The following is a description of a gene set: studied in species Homo sapiens Human Gene Set: chr19q13, and this is the list of marker genes: ZNF180, MYREM, HNRNPL, IGFL1P2, SIGLEC5, ZNF329, AP2S1, ZNF321P (zinc finger protein 321, pseudogene), ZNF574, ZC3H4 (zinc finger CCCH-type containing 4), C19orf18, ZNF606, BLOC1S3, ZFP28, IRF2BP1, GPR42 (G protein-coupled receptor 42), MIR8077, CEACAMP10, ZNF607, MIR6887 (NCBI Gene Id 102466205), KCNN4, DUXA, ZNF223, UBE2CP5, SYCN, HAUS5-DT, MIR517C, RNU6-841P, COX6B1, SIGLEC20P, LIN37, SIGLEC8, RPS29P24, RPS10P28, VASP, LINC01531, MIR6719, IFNL1, ARHGEF1, MIR518A1 (NCBI Gene Id 574488), MIR371B, RNU6-1041P, RPL12P41, IGSF23, RNU6-611P, RASIP1, FUZ, OSCAR, ZNF835, SIGLEC10-AS1, ZSCAN5C, KLK12, LINC01480, MIR8074, LETM1P2, CYP2A13, ISOC2, RPS11, CYP2G2P, ZNF667-AS1, ZNF471, KLK1, MIR4754, ZFP36, GCM1P1, LYPD5, ENSG00000221125, MYADM-AS2, ZNF584-DT, SNORD35B, ERICH4, IRGC, BLVRB, ZNF45, TMEM160, CCDC9, KIR2DL3, ZNF552, SLC8A2, COQ8B, MIR6804, CD177, PSG2, PRPF31, ZNF211, ZNF599, PSENEN, ZNF135, ZNF230-DT, RPS4XP21, VN1R4, PRR13P5, LIN7B, RN7SL154P, SIGLEC17P, LSM14A, ZNF8 (NCBI Gene Id 7554), FFAR2, ETV2, PLA2G4C-AS1, ZNF585B, PSMC4, VSIG10L, PKMYT1AR, ZNF461, IGFL1, RPS9, FXYD3, IGFLR1, ZNF667, PTOV1, RYR1, TMC4, ZNF134, NAPA, BICRA-AS2, AURKC, CGB1, SYNGR4, MIR6800, DLL3, GARIN5B, KIR2DS4, RPS12P31, ZNF841, ZNF324, VN2R19P, RPS4XP23, BICRA-AS1, RTN2, LILRB3, ATF5, MIR8085, KIR3DL2, DEDD2, PNMA8B, ZNF8-DT, NTF6A, SELENOV, NAPSB, MIR6799, LILRA4, EMP3, GSK3A, KLK9 (kallikrein related peptidase 9), KIR3DL3, LINC01595, MIR1283-1, LINC01837, SNORD88B, FBXO27, PAF1, ZNF8-ERVK3-1, CHST8, ZFP82, TPM3P6, KLK6, CTBP2P7, NAT14 (N-acetyltransferase 14 (putative)), MIR515-1, ZSWIM9, SIGLEC14, FPR2, ACP7, MIR525, ZNF807P, CCDC8, ZNF30-AS1, CD177P1, CEACAMP9, RPL9P33, CEACAM22P, PCAT19, CDC42EP5, FAAP24, PSG6, CCDC61, SIGLEC7, BBC3, PHLDB3, KLK8, APOC4-APOC2, ZNF528-AS1 (ZNF528 antisense RNA 1), ZNF415, ZNF568, CLEC11A, FAM187B, DYRK1B, PDCD2L, ZNF586, ZNF383, ZFP14, SRRM5, MIR520C, ZNF222-DT, CLPTM1, MIR6802, ZSCAN1, A1BG-AS1, CEACAMP6, MIR516A1, APLP1, PMIS2, WDR62, C19orf47, C19orf73, NFKBIB, ENSG00000267698, LINC02965, ZNF573, RPL13A, MIR6805, C19orf84, ZNF324B, PLEKHA3P1, ALKBH6, HNRNPDLP4, ZIM2-AS1, ZNF428, VRK3, RN7SL34P, CEACAM7, PSG8, RPS29P30, DMWD, BIRC8, TRAPPC6A, LRFN1, MSRB1P1, MIR512-2, COX6B2, SHANK1, PNKP, APOC1P1, ARPC1AP2, MIR99B, MIR518F, RCN3, PEPD, IFNL4, COX7A1, LENG8-AS1, MIR935, ZNF132-DT, CABP5, CYP2A7P1, ZNF418, KLK13, RPL18, PPP6R1, ACTMAP, SIPA1L3, LINC00904, LGI4, FOSB, NR1H2, ZNF787, RNU6-165P, RPL31P60, FKBP1AP1, SNORA68B, ZNF497, LAIR1, MIR5196, SPACA6, ZNF577, VN1R104P, RFPL4AL1, LENG8 (leukocyte receptor cluster member 8), SIGLEC22P, NIFKP6, CEBPA-DT, ZNF793-AS1, ZNF566, MIRLET7E, MIR522, CEACAM6, CALM3, ACTN4, SYT3, ENSG00000267053, ZNF350-AS1, SMG9, ENSG00000269091, ENSG00000298539, SPTBN4, LINC01864, MIR6797, ZNF507, RPS15AP36, SNORD88A, A1BG, ZNF818P, ZNF579, EID2B, CCDC106, ZNF550, HSPBP1 (NCBI Gene Id 29987), FFAR1, TDRD12 (tudor domain containing 12), GRAMD1A-AS1, PLEKHA4, LIPE, SLC25A36P1, ACP4, PAK4, KIR2DP1, ZNF264, SNRPD2, ZNF226, FPR3, USP29, PINLYP, YIF1B, LIPE-AS1, ZNF470, DKKL1, ZSCAN4, KLK5, RPL21P131, NDUFV2P1, RN7SL364P, RRAS, ZNF613, MIR643, CGB3, KLK11, ZNF227, VN2R17P, FBL, CADM4, SNORD23, ZNF284, ZNF888-AS1, LILRA5, KIR2DL1, SHKBP1, ZNF761, ZNF460-AS1, RNF225, ZNF569, LAIR2, ATP1A3, ZNF582-DT, HSPB6, LYPD4, LINC03078, CLDND2, ZNF285BP, SYT5, VN1R2, LILRA1, PRKCG, ENSG00000269194, ZNF382, PSG11, ENSG00000268833 (novel transcript, antisense to CEACAM6), SNORA70, LILRA6, FAM98C, DBP, LINC00665, NTF6G, SNRNP70, FBXO17, PTH2, ETHE1, SBK3, ZNF548, ENSG00000267058, CYP2F2P, ZNF444, MIR526A2, ZNF790, RNU6-980P, IFNL2, WDR87BP, EXOC3L2, ENSG00000267024, RN7SL566P, SPACA6-AS1, LSR, SIGLEC6, PDCD5, SEC1P, ZIM3, EGLN2, CEACAMP4, ZSCAN5DP, ZNF181 (zinc finger protein 181), ZNF805, ENSG00000268595, THAP8, ZNF221, GPR32, MIR521-2, RPS3AP50, IL11, ZNF587, RPS19, ITPKC, PSMD8, IL4I1, ZNF793, MIR320E, ZNF582, SYNE4, TTC9B, LNROP, ZNF790-AS1, MZF1, ZNF808 (zinc finger protein 808), GPR32P1, ZNF420, RELB, KLK15, RUVBL2, MIR516B1, ZNF446, RPL7P51, TPM3P5, MIR4750, MIA-RAB4B, ZNF114-AS1, MEIS3, APOE, ENSG00000286024, MIR330, TNNT1, ZNF432, ZBTB45, CLIP3, RINL, MIR6088, SNORD88C (small nucleolar RNA, C/D box 88C), ZNF784, HIF3A, SYMPK, ZNF45-AS1, ZNF614, MIR518E, ERFL, SBK2, RAB4B, TOMM40, ZNF567-DT, ZNF155 (NCBI Gene Id 91116), OR5AH1P, MIR519A2, ENSG00000298727, TGIF1P1, SLC1A5, CARD8, EHD2, CPT1C, MIR4323, MYADM-AS1, PNMA8C, PGLYRP1, FIZ1, EDDM13, ZNF175 (NCBI Gene Id 7728), PNMA8A, SELENOW, COX6CP7, ZNF347, MIR518D, DNAJC19P2, CCDC97, KLK2 (NCBI Gene Id 90447), TEX101, TRPM4, TPRX1, DACT3 (NCBI Gene Id 147906), LGALS14, MIMT1, VN1R6P, TMEM277P, MIR518C, ZNF649, MIR512-1, ZNF780B, VN1R107P, DNAJC19P3, RN7SL317P, MAP4K1-AS1, TEAD2, DPF1, GPI, MIR520G, ZNF547 (NCBI Gene Id 284306), HRC, ZNF30, SNRPA, SMIM17, RAB4B-EGLN2, TPM3P9, MIR519D, ZNF543, ZNF132, FUT1, RN7SL789P, MIR520B (NCBI Gene Id 574473), LYPD3, ZNF671, ZNF850, NLRP11, BCAM, PSG3, LIM2-AS1, ZNF229, CYP2B7P, TPRG1LP1, LGALS13, NOP53-AS1, MIR520A, AXL, ZNF888, RNU6-924P, U2AF1L4, SIGLEC10-AS2, LINC01872, SPHK2, BCL2L12, RDH13, BCL3, NAPSA, LILRB2, MIR521-1, PRPF31-AS1, ZNF304, FAM83E, UPK1A-AS1, LILRP2, BRSK1, SNORD34, HAMP, ERVK9-11, MAP4K1, MIR6803, MIR6806, SLC27A5, ZNF566-AS1, RPL36P16, QPCTL (glutaminyl-peptide cyclotransferase like), RPL31P61, RNU6-1337P, MIR520H, FLT3LG, ERCC2, CRIPTOP7, CEACAMP3, KLKP1, ZNF749, MIR3190, RPS16P9, LINC01533, NUDT19, NDUFA3P1, RNU6-945P, SIRT2, NFKBID, MIR520E, SIGLEC11, ZNF702P, IZUMO1, EMC10, GPR4, UBA2, LGALS7B, MYADM, ZNF616, FUT2, CTU1, CGB2, PAFAH1B3, CEACAM4, ZNF542P, RNU6-317P, LILRB4, DMRTC2, CEBPA, CEP89, SLC7A10, RPS16, KIRREL2, ZNF473CR, WDR87, ZNF473, STRN4, IRGQ, MIR6796, FAM90A27P, MARK4, ZNF578, TFPT, PSG9 (pregnancy specific beta-1-glycoprotein 9), NANOS2, PPFIA3, EML2-AS1, ZNF114, SLC6A21P, EXOSC5, RNU6-751P, FOXA3, ENSG00000293116, ZNF571, ZFP28-DT, NLRP4, TEX14BP, AKT1S1, ZNF345, ZNF772, GARRE1, SCGB2B3P, AKT2, RASGRP4, PSG4, CLC, HPN, CATSPERG, ZNF225, CXCL17, PRRG2, MIR519C, RPL37P23, RN7SL836P, KIR3DP1, ZNF302, ZNF580, NLRP2 (NLR family pyrin domain containing 2), ZNF274, ZIM2, SUMO1P4, MAP3K10, ZSCAN5B, HPN-AS1, FKRP, GRAMD1A, TPRX2 (NCBI Gene Id 503627), RPS29P26, CEACAMP11, ZNF837, TBCB, LILRB5, RNU6-902P, CEACAM5, CNFN, AP2A1, ZNF610, RN7SL368P, KCNJ14, HMGN1P32, GIPR, IFNL4P1, SULT2A1, MIR6801 (NCBI Gene Id 102466984), NLRP13, MIR4752, EEF1A1P7, CYP2T3P, PSG7, BSPH1, MIR8061, ENSG00000306458, CENPBD2P, SPINT2, SUPT5H, SIGLEC24P (sialic acid binding Ig like lectin 24, pseudogene), ENSG00000290598, FCGBP, SLC7A9, ZNF28, CRX, ALDH16A1, CLASRP, EID2, MIR641, ZNF222, ZBTB32, SEPTIN7P8, LILRB1-AS1, SLC17A7, IGFL4, TYROBP, U2AF2, RNU6-698P, ZNF587B, GP6-AS1, RPL28, PLEKHG2, RPS29P27, ENSG00000179066, NOSIP, FXYD5, MIR515-2, TIMM50, LGALS7, XRCC1, ASPDH, ZNF628-DT, LINC01530, LRFN3, ERVV-1, DPPA5P1, ECH1, ZNF230, CEACAM20, KCNC3, ZNF576, PRX, MIR519B, HNRNPUL1, ZNF416, ZNF83, FTL, MIR371A, FCAR, ZNF534, FAM187B2P, ENSG00000239137, DHX34, FGF21, ENSG00000269729, GAPDHP38, LINC01535, RPL39P36, DMAC2, ZNF529-AS1 (NCBI Gene Id 101927599), PPIAP59, TTYH1, ENSG00000310422, ZSCAN18 (zinc finger and SCAN domain containing 18), ZNF551, CCER2, IGLON5, ZNF813, MYH14, SERTAD3-AS1, KMT2B, RGS9BP, ENSG00000269151, ZNF154, ZNF224, LMTK3, GEMIN7-AS1, ZSCAN22, CIC, RPS5, MIR4749, MIR519E, KLK7, BAX, KDELR1, ZNF776, LRP3, SNORD32A, IZUMO2, PTPRH, PLA2G4C, DPPA3P8, DNAAF3, ZNF836, CYP2S1, OSTCP3, MIR1323, BICRA, PPP5D1P (PPP5 tetratricopeptide repeat domain containing 1, pseudogene), APOC4, TMEM190, PPP1R14A, ELSPBP1, NUDT19-DT, RPL39P34, SIGLEC9 (NCBI Gene Id 27180), KCTD15, SUNO1, HNRNPA1P52, MIR642B, RN7SL525P, KMT5C, OPA3, LILRB1, ZNF845, SULT2B1, ENSG00000286632, ZNF233, ZNF320, RNU4-60P, MAMSTR, ZNF285, CEACAM1, SIGLEC29P, GP6, POLD1, HAUS5, ZNF225-AS1, MIR642A, RN7SL708P, KIR2DL4, MIR519A1, ZSCAN5A-AS1, CA11, LGALS4, PRKD2, MIR373, CEACAM16-AS1, MED25, LENG1, USF2, KLK4, ZNF546, SAMD4B, ENSG00000267260, WTIP, APOC1, MIR372, VN1R105P, RFPL4AP1 (NCBI Gene Id 646663), TMEM147, CYP2F1, MIR517A, ZNF331, PIH1D1, GPATCH1, PPP1R15A, POLR2I, NTN5, ZNF497-AS1, NOVA2 (NOVA alternative splicing regulator 2), ZNF137P (zinc finger protein 137, pseudogene), C19orf81, BCAT2, TULP2, TBC1D17, ZNF160, IGFL3, RN7SL402P, LIM2, ZNF583, MIR6798, RNU6-140P (NCBI Gene Id 106481221), CEACAMP7, RBM42, FCGRT, UPK1A (uroplakin 1A), CGB8, SBSN, CACNG8, ENSG00000303184, GGN, NUMBL, MIR4751, POU2F2, MIR498, KIR3DX1, LINC02560, ZNF781, ZNF17, IRF3, NUP62, SCGB2B2, SIX5, CEACAM16, CEACAM8, MYPOP, ZFP30 (NCBI Gene Id 400693), TSKS, ZNF524, SIGLEC10, ZNF829, RNU6-982P, NTF4, MIR1283-2, MIR518A2, ERVK3-1, FAM90A28P, MIR520D, CACNG6, NLRP9, ZNF234, RPS26P55, PRR12 (proline rich 12), RN7SL322P, ZIK1, TRIM28, NCCRP1, PTOV1-AS1, KIR3DL1, FBXO46, RNA5SP473, ZNF875, ADM5 (NCBI Gene Id 199800), ZNF260, ZNF404, SHISA7, PPP2R1A, MEIOSIN, SPACA4, GALP, NLRP12, CEACAM3, AKR1B1P7, SNORD35A, PSG8-AS1, CEBPG, GRIK5 (NCBI Gene Id 2901), RN7SKP109, RN7SL526P, ZNF765, KASH5, RSPH6A, ZNF649-AS1, RPS4XP20 (NCBI Gene Id 650710), ZNF350, TNNI3, PLD3, ENSG00000269825, PSG1, ZNF584, DNAAF3-AS1 (DNAAF3 antisense RNA 1), SPIB, ENSG00000298329, ZNF419, MRPS12, MIR516A2 (microRNA 516a-2), ZNF701, ZNF773, MIR527, ZNF540, IGFL2, NLRP7, MED29, SAE1, ZNF460, B3GNT8, CAPNS1, NPAS1, EIF3K, KCNK6, DMKN, FFAR3, ZNF880, RPS29P25 (ribosomal protein S29 pseudogene 25), SERTAD1, ZNF112, SDHAF1, ZNF526, RFPL4A, MIR769, PRR19, CHMP2A (charged multivesicular body protein 2A), WDR88, PRODH2, LINC01838, MIR518B, CACNG7, SNORD33, MIR523, PSG10P, NKG7, CYP2B6, IGFL2-AS1, SCAF1, C5AR1, RNA5SP472, ZNF816, RPL36AP50 (NCBI Gene Id 100271648), VSIG10L-AS1, DMPK, RHPN2, PSG5, ZNF585A, CD22, ZNF814, LHB, TMEM91, NECTIN2, SIGLEC12, LIG1, LTBP4 (NCBI Gene Id 8425), ZNF146, CYP2G1P, ZNF527, ZNF570, ZNF470-DT, SCGB1B2P, MYBPC2 (myosin binding protein C2), POLR1G, CEACAMP5 (CEA cell adhesion molecule pseudogene 5), EML2, PSG11-AS1, LENG9, PLAUR, CNOT3, NPHS1, ZNF606-AS1, DPRX, ZSCAN5A, ENSG00000269172, SIGLEC31P, LINC01801, C5AR2, ZNF296, ZNF571-AS1, IFNL3P1, MIR7975, VSTM1, PROSER3, CBLC (Cbl proto-oncogene C), ZNF468, TSEN34, PRMT1, ZNF529, VN1R1, UBE2S (NCBI Gene Id 27338), MIR150, SIGLECL1, TMEM145, RABAC1, NLRP8, ZNF677, UBE2M, CYTH2, CEACAM19, CCNP, CGB5 (chorionic gonadotropin subunit beta 5), DACT3-AS1, MIR516B2, BCKDHA, ZNF865, CD79A, MIR4531 (NCBI Gene Id 100616355), JOSD2, MIA, PTGIR, GMFG, PEG3, PPP1R13L, MIR5088, EPS8L1, CYP2A6, ETFB, KLK10, FPR1, RN7SL693P, ENSG00000269877, ZNF417, OVOL3, EPN1 (epsin 1), RPL23AP80, LGALS17A, RNU6-1307P, NOP53, CEACAMP8 (CEA cell adhesion molecule pseudogene 8), LINC01782, KLK14, TMEM238, MZF1-AS1, SELENOKP1, TMEM86B, ZNF480, CEACAMP1, PTOV1-AS2, ZNF544, RN7SL150P, PABPN1P2, ERCC1, ZNF665, RN7SL491P, MBOAT7, MIR520F, ANKRD27, NLRP5, ATP4A, APOC2, SAXO3, SARS2, KRTDAP, ZNF792, CAPN12, C19orf48P, PPP1R37, MIR4324, ODAD1, NTF6B, ZNF71, ZNF600, ARHGAP35, ZNF283, ZNF581, PPP5C, EIF5AP3, RPL7AP69, LILRA2, ZNF235, ENSG00000268686, ZNF525, SIGLEC27P, ZNF615, RNU6-195P, RNU6-803P, NUCB1-AS1, DPY19L3-DT, CHCHD2P3, B9D2 (B9 domain containing 2), SIGLEC18P, NDUFA3, HNRNPMP2, FXYD1, CYP2T1P, NUCB1, IFNL3, GEMIN7, GYS1, ZNF256 (NCBI Gene Id 10172), RPL29P33, SIGLEC21P, ZNF530, MIR125A, SIGLEC16, CD37, GRIN2D, RNU6-222P, LILRP1, GNG8, MIR3191, VN1R96P, RN7SL718P, CEACAMP2, MAG, MIR517B (NCBI Gene Id 574483), DM1-AS, CD33, ZNF549, LEUTX, LGALS16, DHDH, ZNF567, KLK3, RN7SKP22, DPY19L3, HAS1, ZNF575, ARHGAP33, ZNF766, NAPA-AS1, LRRC4B, TRAPPC2B, NCR1, PPM1N, MIR4530, ZNF628, INAFM1, GFY, C19orf85 (NCBI Gene Id 111064650), CGB7, KLC3, CKM, ZNF565, MIR526B, PPP1R12C (NCBI Gene Id 79164), SSC5D, ERVV-2, SCN1B, ZNF780A, TYMSP2, ZNF816-ZNF321P, ZNF611, GRWD1, PVR, CYP2A7, TMEM150B, TGFB1, KCNA7, ZNF528, CARD8-AS1, MEGF8, KPTN, LINC01766, TMEM143, HSD17B14, SLC6A16, MIR524, FXYD7, TMEM147-AS1, SERTAD3, CEACAM18, TARM1, NKPD1, ENSG00000268460, HIPK4, GAPDHS, RN7SL663P, GARIN5A, C19orf33, MIR526A1, SMIM47, MIR6807, IGFL1P1, CEACAM21, ZNF541, HCST, ERF (NCBI Gene Id 2077), SPRED3